The following is a description of a gene set: species: Homo sapiens Formation of the canonical BAF (cBAF) complex Human Gene Set: REACTOME_FORMATION_OF_THE_CANONICAL_BAF_CBAF_COMPLEX, and this is the list of marker genes: SMARCA4, SMARCD1, SMARCE1, ACTB, DPF1, BCL7C, ACTL6A, BCL7A, SMARCB1, ARID1B, DPF3, DPF2, SS18, SS18L1, ARID1A, BCL7B, SMARCA2, SMARCC1